Given this list of marker genes RAMP2, CDIN1, HIGD1A (HIG1 hypoxia inducible domain family member 1A), OLFML3, CRNDE, SLIT2, CYB5A, CXCL12, VCAN, COL3A1, MASP1, C7 (NCBI Gene Id 636878), GJA1, CMTM7, H4C3, S100A4, IRX3, EIF2S3, LAMA4, HNRNPL, MYH7, FABP5, TMSB4X, NFIA, EMCN, CD24, LGALS1, ESAM, HAPLN1, HAND1, DGCR6, PDGFD (NCBI Gene Id 80310), DBI, TM4SF1, SCUBE3, MYL2, COX7A1, HEY2, ISOC1 (NCBI Gene Id 51015), FRMD3, TRDN-AS1, RGS3, ATP1A3, LBH, here is a description of the gene set: from publication Cui Y, Zheng Y, Liu X, Yan L, Fan X, Yong J, Hu Y, Dong J, Li Q, Wu X, Gao S, Li J, Wen L, Qiao J, Tang F (PMID 30759401) Human Gene Set: CUI_DEVELOPING_HEART_5TH_WEEK_ATRIAL_CARDIOMYOCYTE species: Homo sapiens